Given this list of marker genes Cxcl5, Cxcl1 (C-X-C motif chemokine ligand 1), F2rl1, Pomc, Arg1, here is a description of the gene set: Any process that modulates the rate, frequency or extent of neutrophil mediated killing of a symbiont cell, the directed killing of a symbiont target cell by a neutrophil. Mouse Gene Set: GOBP_REGULATION_OF_NEUTROPHIL_MEDIATED_KILLING_OF_SYMBIONT_CELL species: Mus musculus